The following is a description of a gene set: Asymmetric localization of PCP proteins Human Gene Set: REACTOME_ASYMMETRIC_LOCALIZATION_OF_PCP_PROTEINS species: Homo sapiens, and this is the list of marker genes: FZD3, PSMA3, PSMD8, ADRM1, VANGL2, SEM1, PSMA4, SMURF1, PSMC3, PSMA7, PSMA1, UBC, PSMD12, FZD8, PSMB3, FZD7, PSMA6, SCRIB, PSMD7, WNT5A, PSMB2, SMURF2, PSMD1, PARD6A, FZD2, PSMD13, PSMC2, FZD5, PSMD11, PSMD14, UBA52, FZD1, PSMB6, PSMB1, UBB, PSMB7, RPS27A, PSMD3, PSMD2, PSMD6, PSMC6, FZD4, PSMB5, PSMC5, PSMC1, PSMC4, PSMA2, DVL2, PSMB4 (NCBI Gene Id 5692), PRICKLE1, PSMA5